Given this list of marker genes Pfkm, Nagk, Pomk, Gnptab, Pfkfb1, Pfkfb2, Gnptg, Gne, Xylb, Hk2, Fggy, Hkdc1, Galk1, Hk3, Pfkfb4, Tkfc, Hk1, Fcsk, Galk2, Rbks, Epm2a, Gck, Khk (NCBI Gene Id 16548), here is a description of the gene set: Mouse Gene Set: GOBP_CARBOHYDRATE_PHOSPHORYLATION The process of introducing a phosphate group into a carbohydrate, any organic compound based on the general formula Cx(H2O)y. species: Mus musculus